The following is a description of a gene set: An abnormality of the Ala of nose. studied in species Homo sapiens Human Gene Set: HP_ABNORMAL_MORPHOLOGY_OF_THE_NASAL_ALAE Abnormal morphology of the nasal alae, and this is the list of marker genes: SCARF2, KIF15, PPP2R1A, PDE4D, RNU4ATAC, DVL3, COL27A1, FZD2 (frizzled class receptor 2), DGCR2 (DiGeorge syndrome critical region gene 2), GDF11, DDX3X, AFF4, ATIC, TMEM218, KANSL1, ACTB, GAD1, AMMECR1, SMARCB1, GPC6, WDR4 (WD repeat domain 4), WNT5A, SLC37A4, SETD1A, PIK3C2A, DOCK3, IQSEC2, SYNGAP1 (NCBI Gene Id 8831), BRAF, EDA, LRPPRC, CEP290, PIK3R1, GNS, HNRNPK, ERCC3, DYRK1A, FBN1, ORC4, ZNHIT3, PEX1, DHCR24, CREBBP, KIF11, CRIPT (CXXC repeat containing interactor of PDZ3 domain), TAF1, MITF, ERCC5, VPS35L, NF1, UFC1, GMNN, KRAS, NEUROD2, ABCA5, BUB1B, KMT2D, ALX1, ESS2, POLRMT (NCBI Gene Id 5442), TRIP12, B9D2, PEX19, DNMT3A, KCTD1, BRD4, B3GLCT, KDM4B, EYA1, ZNF699, PYCR2, ERF, SALL4, GRIN1, KCNJ8, KDM6A, PEX6, DDB1, TCF4, AHDC1, ALX4, KIAA0586, LMBR1, PEX5, EXOSC1, CSNK2A1, DMXL2, MAPK1, FLI1, PLCH1, HECW2, CDC42, PCNT, RNF125, SLC2A1, SCNM1, PLK4, YWHAE, NFIX, MAP2K1, RIC1, IL6ST, FGFR1, CENPJ, CUL7, PPP1R21, RAB3GAP2, PIGF, PMM2 (NCBI Gene Id 5373), PPM1D, CAMTA1, IFT52, MVK, METTL23, B3GALT6, EHMT1, BRCA1, RHOA, FAM149B1, PAICS, ARL13B, SCN2A (NCBI Gene Id 94312), EDNRB, MYH3, DPYD, ADSL, ATP6V1A, MID1, CBY1, FH, IFT74, ARL3, COL3A1, PIGN, DVL1, UBE2A, ARSL, SNX14, RECQL4, NRAS, HES7, CSGALNACT1, ZIC2, CRKL, RPGRIP1L, SH3PXD2B, HRAS, PHF21A (PHD finger protein 21A), CBL, IARS2, KIAA0753, PEX16, PYCR1, PEX10, KCNE5, PAH, AIMP2, ARID1B, NSD1, SKI, RALA, SCN1B, PIBF1, CEP104, HIC1, NEDD4L, SMARCA4, CRIPTO (NCBI Gene Id 6997), RTL1, SIN3A, SMS, WDR19, DIS3L2, ZC4H2, EIF4A2, FGFR2, TRIO, ECEL1, COG8 (NCBI Gene Id 84342), KCNA1, GLUL, IFT122, ALG13, UNC80 (unc-80 homolog, NALCN channel complex subunit), FOXH1, ANKRD17, LTBP3 (latent transforming growth factor beta binding protein 3), PPP1R15B, RERE, NFIA, SETD5, FGD1, NSUN2, GJA8, PTPRF, GJA5, LFNG, KLHL15, PAFAH1B1, SATB2, FILIP1, TMEM216, HOXB1, DLK1 (delta like non-canonical Notch ligand 1), BAP1, SETBP1, SOX11, RPS6KA3, PRKD1, PEX12, PORCN, PDE6D, DEAF1, ASXL1, RMRP, SMC1A, POU1F1, RHOBTB2, SEC23A, ATP6V1B2, COL11A1, AKT1, COG1, TRAF7, PTH1R, COL2A1, MYMX, DHX37, TRPM3, RAI1, TONSL, MADD, DPF2, TBC1D24, SOX10, ARID2, EXOSC2, MPLKIP, PEX13, ANKRD11, RNU4-2, AIFM1, UBR1, KNSTRN, SLC25A46, TMEM138, PLCB3, CACNA1B, ESCO2, TAF4, TWIST1, TBC1D20 (TBC1 domain family member 20), MARS2, TRMT10A, GRM7, CHMP1A, ARID1A, TOGARAM1, GNPTAB, WWOX, VPS51, CTCF, SNRPN, FBXO31, BMP4, SLC6A9, DISP1, PEX26, GRIP1, RAD21, PIGT, ADAMTS3, DNMT3B, MGP, HK1, DHCR7 (7-dehydrocholesterol reductase), MIPEP, HDAC4, PIGQ, LIFR, TMEM53, PAX3, LONP1, CNOT2, GNPAT, TMEM237, TMEM70, KCNJ11, KDM1A, ASH1L, PAX1 (paired box 1), FREM2, ESAM (NCBI Gene Id 90952), EXTL3, SMC3, SKIC3, NAA10, TBX1, MAPK8IP3, AFG2A, DDB2, IDUA, SLC4A10, MEG3, SPOP, EXT2, BRF1, WDR35, AGA, B9D1, INSR, BICRA, TRIM8, POLR3A, RIPK4, CHN1 (NCBI Gene Id 27011), MED12, PUS7, RNF2, ATP6V0A2, ACSL4, PEX14, HNRNPH2, H3-3A, PIEZO2 (NCBI Gene Id 63896), DLL3, VAC14, ZNF423 (NCBI Gene Id 23090), AHI1, ADGRG6, PTEN, SC5D, XYLT1, SMARCE1, SHOC2, PEX2, FGFR3, OFD1, DYNC1I2, IER3IP1, ZNF292, MYCN, TRPV6, CDON, ASXL3, RALGAPA1, TMEM94 (transmembrane protein 94), TRRAP, BLTP1, HYLS1, IFT56, SLC6A1, NARS2, MYMK, ROR2, MAB21L1, NGLY1, SMARCA2, NEXMIF, FLNB, NR2F1, PIGP, SRCAP, XPC, TCTN2, DGCR8, BCL11A, DICER1, MED25, TBCK, ATRX, NOTCH2, FIG4, GPC3, PLOD3, MED12L, PIGA, IFT43, UBE3B, LMBRD2, TUBGCP6, RECQL, BRCC3, CEP41, TAPT1, PUF60 (poly(U) binding splicing factor 60), RDH11, NPHP1, CRLF1, TAF6, FLII, PAK3, FTO (NCBI Gene Id 79068), MN1, KATNIP, SMARCD1, RBM10, GNAI1, USP9X, ACTG2, ATAD3A, TCTN1, RIPPLY2, CSPP1, PEX11B, CERT1, WDR26, MKS1, GCSH, KCNJ6, CLCF1, SCN1A, EFTUD2, TGIF1, DOCK7, AXIN1, GBA1, SIM1, SIX3, CCDC8, PTCH1, NIPBL, SUFU, FRAS1, ALDH6A1, ADAMTSL2, LZTR1, DGCR6, CDC42BPB, POU4F1, GPC4 (glypican 4), DDR2, MSL3, GLI3, PRKAR1A (protein kinase cAMP-dependent type I regulatory subunit alpha), ZBTB24, ALG9, PURA, ZMYM2, KDM5A, NSRP1, ASCC3, TMEM67, FBXO11, CDKL5, CNOT3, PAM16, TRIP11, TXNDC15, BMP2, INPPL1, SPECC1L, PIK3CD, SHH, DLL1, PEX3, PPP1CB, MEGF8, ZSWIM6, PLEC, SOX4, CEP120, NXN, CTNNB1, CKAP2L, WLS, ATP6V1E1, FRMD4A, ELN, MYO18B, CWC27, NODAL, CDH11, PNKP, MLXIPL, USB1, EDN3, NOVA2, COL11A2, TRPS1, PPP2R3C (protein phosphatase 2 regulatory subunit B''gamma), ERCC4, INPP5E, SIK1, SLC32A1 (NCBI Gene Id 140679), NFIB, SMARCC2, EBF3, MECP2, HDAC8, CEP55, OCLN, FGF3, CCNK, ERCC2, ZBTB20, TXNL4A, ADNP, HPDL, CPSF3, CPLANE1, ABCC9, PARS2, H4C5, CASK, GPAA1, SMG9, BCR, CC2D2A, CLP1, CANT1, EDEM3, RAC1, XPA, TOR1A, GLI2, ARX, MEF2C, KCNH1, ANTXR1 (NCBI Gene Id 84168), SLC17A5, POLR1A, TUBGCP4, MAP2K2, FGF8, MTX2, KIF14, EXT1, SLC29A3, TMLHE, GNAO1, IRX5, AP2M1 (NCBI Gene Id 1173), SLC25A22, GJA1, TWIST2, SLC26A2, MED27, TMCO1, RAB18, PRPS1, POLG2 (NCBI Gene Id 11232), EIF5A, PDHA1, AUTS2, OBSL1, TCTN3, CHD2, TP63, SPTBN1, RAB3GAP1, SPEN, PRMT7 (NCBI Gene Id 54496), HIVEP2, NOG, PBX1, NALCN, CD96, FAM20C, MESP2, MAFB, GAS1, SMOC1, PHIP, TMEM231, PIGY, ARMC9, KATNB1, RBM8A, ZNF462, SUMF1, TBX6, MICU1, RAC3, ABCC8, MAP3K7, CHD6